Given this list of marker genes FGFR2, BMP5, IGF2, ZNF568, WNT7B, SPINT1, GRB2, NCOA1, ZFP36L1, TMED2, SPINT2, DNAJB6, LEF1, ST14, RSPO3, ADM, CDKN1C, GCM1, GJB5, LLGL2, SOCS3, GRHL2, FZD5, CCN1, BMP7, IL10, TRIM28, here is a description of the gene set: The process in which the embryonic placenta is generated and organized. Human Gene Set: GOBP_EMBRYONIC_PLACENTA_MORPHOGENESIS species: Homo sapiens